Given this list of marker genes SULT6B1, SULT1C2, SULT2B1, SULT1B1 (sulfotransferase family 1B member 1), SULT1A4, SULT1E1, SULT2A1, G6PD, SULT1A2, GSR, SLX1A-SULT1A3 (NCBI Gene Id 101929857), PAPSS2, SULT1C3, SULT1A1, SULT1C4, PAPSS1, SULT4A1, here is a description of the gene set: Human Gene Set: WP_SULFATION_BIOTRANSFORMATION_REACTION Sulfation biotransformation reaction species: Homo sapiens